Given this list of marker genes TRPV1 (NCBI Gene Id 7442), HTR2A, TACR1, ATP2B4, P2RX2, TRPA1, TBX3, KCNMA1, P2RX3, TBX2, here is a description of the gene set: A process in which force is generated within smooth muscle tissue, resulting in a change in muscle geometry. This process occurs in the urinary tract. Force generation involves a chemo-mechanical energy conversion step that is carried out by the actin/myosin complex activity, which generates force through ATP hydrolysis. The urinary tract consists of organs of the body that produce and discharge urine. These include the kidneys, ureters, bladder, and urethra. species: Homo sapiens Human Gene Set: GOBP_URINARY_TRACT_SMOOTH_MUSCLE_CONTRACTION